The following is a description of a gene set: Any process that modulates the frequency, rate or extent of chloride transport. studied in species Mus musculus Mouse Gene Set: GOBP_REGULATION_OF_CHLORIDE_TRANSPORT, and this is the list of marker genes: Car2, Abcb1a, Atp8b1, Prkg2, Car7, Abcb1b